Given this list of marker genes AMBP, ABCC2, SLCO1B3, HMOX2, BLVRA, ABCC1, HMOX1, UROD, BLVRB, SLCO2B1, UGT1A1, UGT1A4, SLCO1B1 (solute carrier organic anion transporter family member 1B1), here is a description of the gene set: species: Homo sapiens Human Gene Set: GOBP_TETRAPYRROLE_CATABOLIC_PROCESS The chemical reactions and pathways leading to the breakdown of tetrapyrroles, natural pigments containing four pyrrole rings joined by one-carbon units linking position 2 of one pyrrole ring to position 5 of the next.